Given this list of marker genes Pitx1, Otp, Gli1, Bmp4, Hes1, Ghrh, Six3, Tcf7l2, Aldh1a2, Kdm1a, Wnt5a, Inhbb, Slc6a3, Pcsk1, Bmp2, Gata2, Bmpr1a, Pou1f1, Wnt4, Fgf2, Sox2, Gli2, Rbpj, Tbx19, Lhx3, Sox3, Creb1, Hmga2, Gsx1, Duox2, Ghrhr, Nkx2-1, Adcyap1, Drd2, Hesx1, Nog, Fgf8, Pou3f2, Pitx2, Pax6, Fgf10, Prop1, Isl1, here is a description of the gene set: The progression of the pituitary gland over time from its initial formation until its mature state. The pituitary gland is an endocrine gland that secretes hormones that regulate many other glands. studied in species Mus musculus Mouse Gene Set: GOBP_PITUITARY_GLAND_DEVELOPMENT